Given this list of marker genes Glra1 (NCBI Gene Id 320836), Glra4, Chrm5, Glrb, Glra2 (NCBI Gene Id 237213), Glra3, here is a description of the gene set: studied in species Mus musculus Mouse Gene Set: GOMF_EXTRACELLULARLY_GLYCINE_GATED_CHLORIDE_CHANNEL_ACTIVITY Enables the transmembrane transfer of a chloride ion by a channel that opens when glycine is bound by the channel complex or one of its constituent parts on the extracellular side of the plasma membrane.